The following is a description of a gene set: Human Gene Set: GOBP_INNATE_IMMUNE_RESPONSE_ACTIVATING_CELL_SURFACE_RECEPTOR_SIGNALING_PATHWAY The series of molecular signals initiated by a ligand binding to a cell surface receptor that leads to the activation of an innate immune response. species: Homo sapiens, and this is the list of marker genes: MIR210, PAK1, NR1D1, FCN1, RAB11FIP2, MYD88, F2RL1, TYROBP, KLRD1, PIK3AP1, TMEM126A, TICAM1, RELA, TLR6, FYN, KLRK1, KLRC4-KLRK1, CYBA (NCBI Gene Id 1535), NR1H3, PRKCE, TICAM2, IRAK2, LGALS9, TREM2, TRIL, KIR2DS2, TBK1, ACOD1, DAB2IP, MAP3K7, COLEC11, FCN3, TAX1BP1, NMI, HMGB1, NFKBIA, TRIM32, KLRC1, PJA2, MIR146A, KLRC4, PAK3, APPL1, KLRC2, CD14, LBP, MIR20A, MIR708, S100A14, CLEC6A, TRAF3, OAS1, MBL2, MIR149, IRAK1, SYK, KLRC3, LETMD1, TIRAP, CLEC7A, CHUK, TLR1, PAK2, LILRA2, NINJ1, RIPK2, APPL2, TNFAIP3, FCN2, TRAF6, FFAR2, TLR2, EP300, PTPN22, IKBKB, PLCG2, WDFY1, TNIP3, SRC, PIK3R1, LTF, IRF3, LY96, FLOT1, NAGLU, RAB7B, SCIMP, ECSIT, COLEC10, MIR140, SQSTM1, BPIFB1, TNIP2 (TNFAIP3 interacting protein 2), TLR5 (NCBI Gene Id 95519), IFI35, TLR4 (NCBI Gene Id 7099), LYN, CREBBP, MFHAS1, MIR200C, ZNRF1, IRAK4, MIR200B, PELI1